Given this list of marker genes Cdc25c, Cnot10, Cnot7, Cenpj, Npm1, Tnks1bp1 (NCBI Gene Id 228140), Cnot4, Plk2, here is a description of the gene set: This event has been computationally inferred from an event that has been demonstrated in another species.<p>The inference is based on the homology mapping from PANTHER. Briefly, reactions for which all involved PhysicalEntities (in input, output and catalyst) have a mapped orthologue/paralogue (for complexes at least 75% of components must have a mapping) are inferred to the other species. part of: TP53 Regulates Transcription of Cell Cycle Genes Reactome Pathway: TP53 regulates transcription of additional cell cycle genes whose exact role in the p53 pathway remain uncertain species: Mus musculus electronically inferred by orthology from the curated human pathway